Given this list of marker genes PIK3CG (NCBI Gene Id 5294), SORL1, APOC3, GPLD1, APOC1, PLIN5, here is a description of the gene set: Any process that decreases the frequency, rate, or extent of the chemical reactions and pathways resulting in the breakdown of triglyceride. studied in species Homo sapiens Human Gene Set: GOBP_NEGATIVE_REGULATION_OF_TRIGLYCERIDE_CATABOLIC_PROCESS